The following is a description of a gene set: Any structural abnormality of the female external genitalia. Abnormal female external genitalia morphology Human Gene Set: HP_ABNORMAL_FEMALE_EXTERNAL_GENITALIA_MORPHOLOGY studied in species Homo sapiens, and this is the list of marker genes: TALDO1, DHH, SMC1A, PLAGL1, PEX19, UBR1, POR, WT1, MED25, IRF6, MINPP1, LUZP1, DHCR24, WNT5A, ROR2, ATR, BRD4, SKI, SETBP1, PEX3, CYP11B1, CHD7, MMP23B, ISL1, LMNA, NIPBL, CD96 (CD96 molecule), CDC45, PRKAR1A, CAVIN1, MAP3K1, B3GLCT, NR5A1, TRAIP, LIPE, RSPO1, POC1A, TWIST2, PORCN, KAT6B, SNORD115-1, RAB3GAP1, SNRPN, RAB3GAP2, NR3C1, SMC3, PRKCZ, PEX11B (peroxisomal biogenesis factor 11 beta), HSPG2, RAD21, VAC14, NXN, GATA4, PEX16, PMM2, CASZ1 (NCBI Gene Id 654487), UBE3B, KCNAB2, ZFPM2, NSUN2, NPAP1, FIG4, SMARCA2, FGFR2, NR0B1, SNORD116-1, DVL1, PRDM16, FREM2, HERC2, ESR2, AR, CAV1, TBX15, SRY, PPARG (peroxisome proliferator activated receptor gamma), PEX5, MAGEL2, UBE4B, PEX6, ORC6 (origin recognition complex subunit 6), SMCHD1, CXCR4, PCNT, SEMA3E, PEX12, PEX1, DVL3, CDC6, PDPN (NCBI Gene Id 29912), HDAC8, ARID1B, CYP19A1, RIPK4, GAD1, FRAS1, GABRD, HYMAI, SIM1, CEP152, PEX14, LIG4, FDXR, GMNN, MYH3, ECEL1, TBC1D20, PEX10, CCNQ, GRIP1, DHX37, SOX9, MKS1, PEX2, RAB18, COX7B, SPEN, CDT1, PEX13 (NCBI Gene Id 5194), FOS (Fos proto-oncogene, AP-1 transcription factor subunit), PPP1R12A, TAF6, CTCF, TOE1, NDN, PDE4D, PPP2R3C, VAMP7, MKRN3, NDUFB11, CHRNG, BSCL2, CYP11A1, MAB21L1, PWAR1, TP63, AGPAT2, HSD3B2, ORC1, RERE, DHCR7, HNRNPR, PEX26, INSR, ORC4, MOGS (NCBI Gene Id 7841), ACTB, ATIC, SPECC1L, HCCS, CBX2, SLC25A24, WWOX, TNXB, OCA2, PWRN1, ESCO2, FZD2, RAC3